Given this list of marker genes MSRB3, PIP4P1, FZD4, ZNF655, DCUN1D3, GFAP, PIEZO2, ITSN2, KRT15, NSMF, ARHGAP12, DTNB, NUP98, C9orf163 (chromosome 9 putative open reading frame 163), THRB, C10orf105, USP46, SUV39H1, CDHR1, TIAM1, LPAR5 (NCBI Gene Id 57121), ARMC1, PARP14, PLEKHH1, NUP58, IKBKB (inhibitor of nuclear factor kappa B kinase subunit beta), PSD3, PAK2, ARID1B, IBA57, PRDM1, ACTRT3, KDM7A, DDN, OSTM1, KHDRBS1, SLC9A6, ESR1, PRDM2, EIF4EBP1, TIMM22, SATB2, SLC12A5, AKAP10, NUFIP2, CYB561D1, SLC25A11, PCDHGA12, DOCK3, MBLAC2, HTR2C, ARID3B, CPLX2, SKIDA1, FMR1, CRCP, OTX2, COL12A1, CRTC1, PDE1B, PHLDB2, WAPL (NCBI Gene Id 23063, WAPL cohesin release factor), RIPOR1, FHIP2A, SNX24, SLC17A7, RNF121, XKR7, DNMT3B, FAM53C, HSPB7, KBTBD13, TIPARP, PPIF, CORO1C, GLI3, SIN3A, RFTN1, FRAT1, HAPLN1, HIF1AN, RNF44, GLYCTK, RNF213, ZNF518A, ACHE, HOMER2, LEP, CD81, JOSD1, RUNX1T1, SH3TC2, CDK2 (cyclin dependent kinase 2), ZNF618 (NCBI Gene Id 4740), RASAL2, KCNK9, NSD1, PTPN12, UBTD1, ATXN1, DYNLT3, here is a description of the gene set: Genes predicted to be targets of miRBase v22 microRNA hsa-miR-7976 in miRDB v6.0 with MirTarget v4 prediction scores > 80 (high confidence targets). Human Gene Set: MIR7976 species: Homo sapiens from publication Chen Y, Wang X (PMID 31504780)